Given this list of marker genes VTA1, VPS4B, RAB11A, VPS37D, SNF8, VPS25, VPS4A, VPS37A, VPS37B, VPS36, CHMP5, MVB12A, VPS37C (VPS37C subunit of ESCRT-I), PDCD6IP, IST1, VPS28, RAB27A, CHMP1B, STAM, CHMP7, CHMP2B, CHMP4C, CHMP4A, MVB12B, CHMP3 (NCBI Gene Id 51652), CHMP6, HGS, CHMP1A, CHMP2A, STAM2, UBAP1, TSG101, CHMP4B, here is a description of the gene set: Human Gene Set: GOBP_MULTIVESICULAR_BODY_ORGANIZATION studied in species Homo sapiens A process that is carried out at the cellular level which results in the assembly, arrangement of constituent parts, or disassembly of a multivesicular body. A multivesicular body is a type of late endosome in which regions of the limiting endosomal membrane invaginate to form internal vesicles; membrane proteins that enter the internal vesicles are sequestered from the cytoplasm.